The following is a description of a gene set: Genes predicted to be targets of miRBase v22 microRNA mmu_miR_7066_5p in miRDB v6.0 with MirTarget v4 prediction scores > 80 (high confidence targets). from publication Chen Y, Wang X (PMID 31504780) Mouse Gene Set: MIR_7066_5P studied in species Mus musculus, and this is the list of marker genes: Micos10, Znrf1, Phldb1, Coro1b, Caln1, Scgb2b27, Klhl24, Adam5, Ddn, Tpgs2, Nol3, Sptlc3, Nlgn3, Ahnak, Mob3b, Gas7, Nsd1, Zfp473 (zinc finger protein 473), Klhl14, Higd1a, Rabep1, Ebi3, Atp1b4, Bsg, Cep128, Foxj3, Etf1, Faf1, Izumo1r, Kidins220, Tenm3, Scgb2b26, Tbc1d8, Aqp5, Exosc1, Ube2w, Tmod2, Cnih2, Ppp3ca, Zfp867, Csf1, Rora, P2rx7, Serpina6, Tenm4, Susd1, Gcn1, Cpm, Crbn, Chtf8, Txndc17, Zic2, Mrpl49, Kcnb1, Slc46a2, Crtc1, Il4ra, Mmp14, Peg3, Rnf222, Neu2, Tnr, Epb41l1